Given this list of marker genes DNMT1, SLC25A13, NAGS, MMACHC, ALAD, RYR1, PRDX1, OTC, FIG4 (FIG4 phosphoinositide 5-phosphatase), MT-TE, here is a description of the gene set: Human Gene Set: HP_DELIRIUM A state of sudden and severe confusion. studied in species Homo sapiens Delirium